Given this list of marker genes GABBR1, ACAP3 (ArfGAP with coiled-coil, ankyrin repeat and PH domains 3), PHLDA3, HPGD, ARID3A, OSBPL1A, SLC35D2, RHOA, TSC22D1, TBC1D10A, SLC37A4, FKBP2, IL12RB1, TRPV2, NPNT, LZTS1, DNASE1L1, CNIH4, ARHGAP45, FRMD5, TCTA, CTPS2, ACADS (NCBI Gene Id 35), CDKN2B, FAF1, TATDN2, VIM, IER2, RAB7A, LGALS3, TAFA3, PLEC, RASGRF1, SLC41A2, YPEL2, PCSK1, CCR1, CCDC61, SPECC1, CASTOR2, FBXO6, ZFP36, CDIPT, SELENOF, ASPH, EEF2K, CASP6, NADK (NCBI Gene Id 65220), NDRG1, MSRB3, SLC39A7, SNX9, TPD52, RAMP1 (NCBI Gene Id 10267), ERMP1, ALDH9A1, ATP6V0B, YWHAB, PROS1, PLEKHO2, BCKDHA, ARRB1, VPS26A, EML3, LEPROTL1, IFI35, PIGL, COL12A1, NDRG2, LRP8 (NCBI Gene Id 7804), DHX16 (NCBI Gene Id 8449), CD48, LONP2, HSF2, COL18A1, DHCR24, CCNG2, TMOD3, CPNE2, CTNNA1, GLUL, CCDC91, ATP8A1, LMNA, ATP6AP2, MGAT4B (NCBI Gene Id 11282), GALE, PTPN5, NEB, DBNL, GPX1, LTB4R, COTL1, PPM1J, ACOT6, SLC37A2, PIGM, FAH, SLC36A1, ACSS2, S100A11, FMOD, CYBA, GTF2H5, JUP, SP6, TMTC2, MARCHF8, APBB1, ARHGAP23, MT1A, HPS6, GPR146, AFDN, SIDT2, EZR (NCBI Gene Id 7430), DMBX1, RTN4, LZTR1, AP3S1, BLOC1S4, MID1IP1, ATF6, MT2A, RIPK3, SCP2, FBXL12, SELENOP, CMTM6, LGALS1, HM13, NEO1, SYPL1, MCUB, HECTD3, TRIM3, SLC9A6, CD247, MFSD11, PLXNA1, PRKAR1A, NDUFS5, SNX29, RAB20, HMGCS1, TNFRSF8, CST3, SEPTIN11, BRPF1, ACLY, CORO2A, TMED8, DIPK1A (NCBI Gene Id 388650), RASGRP2, SREBF2, SAMD12, SLC31A2, RPS6KA1, TMBIM6, MMP25, CAPN2, PKN1, MAP2K2, GALNT1, AGTPBP1, ECHDC2, SNAPC5, FOS, SYF2, NXT2 (NCBI Gene Id 55916), CCR3, MLF1, CTBP2, GPAT3, CD44, ACBD4, BCO2, ATP6V0A1, BAX, ERLIN2, H2BC4, GM2A, here is a description of the gene set: Expression profiling of Rag2-deficient Ets1++ and Rag2-deficient Ets1-- mature NK cells and WT bone marrow progenitors, WT T cells, and WT Pro B cells from publication Ramirez K, Chandler KJ, Spaulding C, Zandi S, Sigvardsson M, Graves BJ, Kee BL (PMID 22608498) Human Gene Set: GSE37301_PRO_BCELL_VS_RAG2_KO_NK_CELL_UP Genes up-regulated in pro-B cells versus RAG2 knockout NK cells. studied in species Homo sapiens